Given this list of marker genes ART1, DEFA5, PRSS3, CD4, DEFA1B, PRSS2, DEFA4, DEFA1, DEFA3, DEFA6, here is a description of the gene set: Human Gene Set: REACTOME_ALPHA_DEFENSINS studied in species Homo sapiens Alpha-defensins